Given this list of marker genes GABRA3, GALNT3, POU6F2, GTF2IRD2, SLC12A1, BTK, REST, TRIP13, DGCR6, CACNA1C, MLXIPL (NCBI Gene Id 51085), NOTCH3, TCIRG1, RFC2, CLDN10, SAMD9, PLVAP, CLDN16, CDKN1B, ALDOB, CCDC134, CDC73, SDHC, CNNM2, TBL2, GP1BB, APC2, TMEM38B, WT1, CLCN7, GTF2I, BCL6, CA2, UBR1, COMT, LIMK1, BTNL2, IFT122, ENPP1, CMPK2, DGCR8, FOXP3, EPAS1, MIR140, FOXN1, DMP1 (NCBI Gene Id 1758), ARVCF, SLC12A3, CYP2R1, FKBP6, CDKN1C, FXYD2, RRAGD, SARS2, KCNJ18, SLC39A14, BUD23, TBCE, SLC34A3, SLC34A1, TRIM28, ACADVL, RYR1, PTH1R, PDGFB, KCNJ1, GTF2IRD1, STX1A, SDHD, MDH2, TRPS1, ZFX, VDR, BSND, BAZ1B, SLC39A8, HADHA, CDKN2C, GPC3, NF1, GCM2, KL, PCBD1, SLC3A1, GNAS-AS1, DNMT3A, CACNA1S, RREB1, SLC4A1, SDHB, LDHA, SLC30A10, AP1S3, ORAI1, ADAMTS3, SDHA, H19, SLC5A1, BRCA2, CYP3A4, ALG12, HIRA, TIAM1, FAT4, RFX7, SLC20A2, SDHAF2, CRELD1, AP2S1, OSTM1, AIRE, CAMKMT, DGCR2, PLEKHM1, KCNJ10, DIS3L2, TMEM127, LPIN1, FGF23, CLDN19, METTL27, POLRMT, VHL, FAM111A, NCF1, CLCNKA, TNFRSF11A, STX16, MT-CO1, TRIO, DNAJC30, HLA-DQA1, GNA11, GNB2, HADHB, RMRP, CSF1R, MAX, SLC25A11, PHEX, TBX1, CCND1, CDKN2B, EGF, IVD, FARSB (NCBI Gene Id 112957), DLST, PIGT, MT-CO3, ELN, BCL2 (NCBI Gene Id 596), IL36RN, CYP27B1, USP53, MEN1, ESS2, CASR, NSD1, EIF4H, HLA-DRB1, UFD1, PDGFRB, KIF1B, CAV1 (NCBI Gene Id 857), RET, PIK3C2A, GEMIN4, CHD7, CYP24A1, FOCAD, SNX10, SEC24C, CTNS, PPM1B, TNFSF11, GNAS, CLCNKB, DBH, HLA-DQB1 (major histocompatibility complex, class II, DQ beta 1), SLC34A2, TMEM270, CCBE1, ALPL, ADCY10, GATA3, VPS37D (NCBI Gene Id 171020), FH, PTH, OBSCN, CLIP2, PREPL, ANKH (NCBI Gene Id 7995), CDKN1A, JMJD1C, ATP1A1, TRPM6, here is a description of the gene set: species: Homo sapiens Abnormal blood inorganic cation concentration Human Gene Set: HP_ABNORMAL_BLOOD_INORGANIC_CATION_CONCENTRATION An abnormality of divalent inorganic cation homeostasis.